Given this list of marker genes DAXX, PPIF, ZC3H12A, GSTO2, UROS, MKNK2, DDX3X, ZFAND2A, MAPK13, ZFAND1, VCP, HSF1, HNRNPA1, HMOX1, DHX36, SLC38A2, GSTO1, here is a description of the gene set: Any process that results in a change in state or activity of a cell (in terms of movement, secretion, enzyme production, gene expression, etc.) as a result of an arsenic stimulus from compounds containing arsenic, including arsenates, arsenites, and arsenides. studied in species Homo sapiens Human Gene Set: GOBP_CELLULAR_RESPONSE_TO_ARSENIC_CONTAINING_SUBSTANCE